The following is a description of a gene set: Human Gene Set: MIR192_3P from publication Chen Y, Wang X (PMID 31504780) Genes predicted to be targets of miRBase v22 microRNA hsa-miR-192-3p in miRDB v6.0 with MirTarget v4 prediction scores > 80 (high confidence targets). species: Homo sapiens, and this is the list of marker genes: TMED2, GABRB2, MAP3K2, UBE2Q2, ATP6V1G2, BEND4 (NCBI Gene Id 389206), NFKBIZ, CHMP4C, HS6ST3, TRERF1, ZNF318, MAP7, UBR2, BDNF, NFAT5, PHYKPL, CCNE2, CASD1, EDN3 (NCBI Gene Id 1908), SLC35F3, RAB1A, PKN2, USO1, FZD4, CD46 (NCBI Gene Id 4272), FUT11, METAP2, MYLK, FLG2, BMPR2, KDELR2, SESN3, LRAT, DTD2, RNF11, ZC3H6, RNF212, DPF3, NR1H4, ALOX15, RPS6KA6, ZNF254, EBF2, TMOD2, SV2C, KANSL1, BRWD3, TMEM117, PRRG1, CDC27, FOXF1, TSHZ3, SRSF1, FRS2, TEAD1, ZNF561, GABRA4, UBE2G1, DLEU7, TAPT1, NSD3, TMED7, TMTC2, ABL2, STK39, RHEX, ESYT3, ZNF608, KLHL1, TTYH2, FAS, WIPF3, CLCN3, BTBD6, DAB1, C6orf120, USP44 (ubiquitin specific peptidase 44), TMEM187, FRY, ZEB2, CAMK2N1, TCEA1, ARL5A, PLEKHO2, IL17RD, TOB1, COLEC10, RNF6, SPIRE1, C16orf87, CC2D2A, ST8SIA1, GOLPH3, ZC3H12C, POLR2C, AMFR, IGF2BP1, IGF2, CCDC14, GRAP2 (GRB2 related adaptor protein 2), TAGAP